Given this list of marker genes Hsp90b1, Eef1ece2, Pcsk6, Cma1, Pcsk2, Pcsk4, Ren1, Pcsk1, Prcp, Yipf5, Pcsk1n, Ece2, Slc30a5, Ero1b, Chst8, Gm15441, P4hb, Mep1a (NCBI Gene Id 17287), Prep, Disp1, Anpep, Ece1, Ins2, Adam10, Hid1 (NCBI Gene Id 217310), Scg5, Adam17, Corin, Mme, Enpep, Ace2, Ctsl, Pcsk5, Furin, Cstl1, Bace2, Atp6ap2 (ATPase, H+ transporting, lysosomal accessory protein 2), Bace1, Cpa3, Casp1, Ace, Slc30a8, Cpe, here is a description of the gene set: Mouse Gene Set: GOBP_SIGNALING_RECEPTOR_LIGAND_PRECURSOR_PROCESSING studied in species Mus musculus The cleavage of a peptide bond in a precursor form of a signaling receptor ligand, resulting in the mature (active) form of the ligand.